The following is a description of a gene set: Abnormal circulating C-peptide concentration An anomalous circulating concentration of the connecting (C) peptide, which links the insulin A and B chains in proinsulin, providing thereby a means to promote their efficient folding and assembly in the endoplasmic reticulum during insulin biosynthesis. After cleavage of proinsulin, C-peptide is stored with insulin in the soluble phase of the secretory granules and is subsequently released in equimolar amounts with insulin, providing a useful independent indicator of insulin secretion. Human Gene Set: HP_ABNORMAL_CIRCULATING_C_PEPTIDE_CONCENTRATION species: Homo sapiens, and this is the list of marker genes: NEUROD1, PPARG, PAX4, HNF4A, AGPAT2, BLK, CNOT1, CIDEC, PDX1, CEL, INS, ABCC8, CAVIN1, HADH, STAT6, BSCL2, SLC25A36 (NCBI Gene Id 55186), APPL1, FOS, UCP2, HNF1A, KLF11 (NCBI Gene Id 8462), KCNJ11, CAV1, INSR, NAB2, GCK